Given this list of marker genes SLC8A1, SLC47A2, ARL2, RAB11FIP2, SLC38A2, RYR2, SLC22A4, ATP4A, SLC27A1, HMOX1, SLC25A4, TRPC7, NIPA1, SLC39A5, ANO4, GNG10, SLC41A2, ATP6V1A, SLC5A6, UBA52, CYBRD1, SLC24A1, ATP6V1E2, SLC17A7, SLC25A5, AQP10, AQP7, APOB, FTH1 (ferritin heavy chain 1), SLCO4C1, PSMA2, GNAS, DERL1, PSMD14, SLC40A1, SLC29A2 (NCBI Gene Id 3177), MCOLN2, ABCG8, PHB2, SLC26A6, SLC35D1, ABCD3, SLC26A11, CLCN6, ATP6V0A4, ABCC11, NGB, TRPA1, ATP2A2, LETM1, SLC3A1, ATP1A2, APOBR, UBB, ADRM1, PEX19, FXYD6, WNK2, SLC17A3, GLRX3, APOA2, VDAC2, EMB, GNB3, ATP8B1, SLC8A2, A2M, SLC22A6, DERL3, SLC5A11, CLCA1, BMP1, ABCB8, ATP6V1G2, EIF2S1, SLC15A4, SLC5A4, SLC30A10, ANO9, ESYT2 (extended synaptotagmin 2), SLC27A4, ATP4B, MIP, FXYD1 (NCBI Gene Id 5348), SLC8A3, SLC20A1, SLC25A6, PSMA7, PLEKHA8, SLC17A1, SLC31A1, SLC7A5, ANO3, SEL1L (SEL1L adaptor subunit of SYVN1 ubiquitin ligase), ATP6V1F, ATP9A, ADD3, SLC1A7, ERLEC1, AP2A2, SGK3, TPCN2, ABCB7, ATP6V1G3, ATP6V0D2, RNF185, MMGT1, SLC7A2 (solute carrier family 7 member 2), SPG7, GNG11, ABCC3, SLC26A9, APOC3, ADCY3, LIPA, SLC7A8 (NCBI Gene Id 23428), CIDEC, SAR1B, SLC26A3, ATP11B, ABCA5, SLC13A3, SLC43A2, SLC2A12, ATP11A, CES3, SLC43A1, MCOLN3, CAMK2G, SLC2A4, SLC35A3, NPC1, SLC28A1, GPIHBP1, ABCB6, ATP6V1D, SLC38A1, SLC12A3, SLC35B3, PSMD13, CUTC, SLC39A7, SLC2A1, SLC6A6, SLC38A4, RUNX1 (NCBI Gene Id 861), CLIC2, SLCO1C1, ATP2A1, BSG, ATP1B1, PSMC1, ANGPTL3, SLC2A6, SLC24A3, MBTPS2, PSMB7, TRPM4, HEPH, FTMT, RIPK1, IREB2, ASIC1, ABCG4, SLC45A3, STEAP4, ANO5, ATP1A3, SCARB1, EIF2S2, PSMC6, MYO5B, WNK4, SLC2A2 (NCBI Gene Id 6514), SLC7A3, ACO1, MAGT1, SLC39A6, FGF21, HBB, ANKH, CYGB, PRKAR2A, SLC44A4 (NCBI Gene Id 87892), SLC8B1, AVP, SLC25A11, SLC39A14, FURIN, PSMC2, PCSK6, PSMB2, CPTP, AKAP1, ATP2B1, SLC38A3, SLC6A15, ABCA10, SLC17A5, AP2A1, PSMA1, SOAT2, SLC38A5, DERL2, SLC9A6, SLCO2A1, SLC4A4, PSMB4, SRI, SLC30A5 (solute carrier family 30 member 5), SLC9A8, SLC1A5, SLC9B1, CLN3, CYB5R4, WNK1, PSMC3, NIPAL4, PSMB6, SLC25A22, NCEH1, SLC5A3, SLC22A3, CAMK2D (NCBI Gene Id 817), PSMA3, MIR32, SLC17A6, LMF2, APOC4, APOC2, ASIC5, APOA4, UBC, NR1H3, ABCA8, AP2S1, PRKACG, TF, SLCO2B1, ALAD, CYB5R2, TRPM3, AQP12A, GNG8, SLC16A7, TRDN, ATP8B4, TRPV3, RHAG, PARL, STOML3, SLC12A5, ADCY5, SLC1A1, BEST2, AQP5, SLC34A2, NPC2, ABCG2, ATP8A1, ATP2A3, TRPV2, RIPK3, SLC6A1, ABCC6, SLC16A8, GNB2, APOE, SLC9A9, GNG3, OS9, ATP6V1H, ATP9B (ATPase phospholipid transporting 9B (putative)), CSN1S1, TRPC4, ABCA6, UNC80, CLCA4, SLC24A5, SLC5A8, APOA1, SLC22A17, ATP2C2, SLC22A1, SLC67A1, GNG5, SLC4A1, PSMD11, SLC39A2, SLC4A2, SLC1A2, SLC25A29, ATP10A, CLCN3, AZGP1, CASQ2, FXYD2, LSR, TFRC, FXYD4, CUL1, SLC4A10, HDLBP, AHCYL2, SLC29A1, ATP6V0E1, RHBG, ADCY6, SCNN1G, SLC30A3, SLC7A10, MICU3, TTYH1, SLC2A10, DMTN, SLC7A7 (NCBI Gene Id 9056), RYR1, ATP6V1C1, ABCD1, TRPV6, SLC24A4, LRRC8B, SLC15A1 (NCBI Gene Id 6564), AQP6, FXYD3, CLCN5, SLC29A4, BEST4, SLCO1B1, SLC9A2 (solute carrier family 9 member A2), AQP11, ERLIN1, SEM1, ATP2B4, MB (myoglobin), ATP13A2, ATP6V0C, CAMK2A, CLTA, PCSK9, CREB3L3, LRRC8D, ADCY2, ATP1B2, ABCG1 (NCBI Gene Id 9619), PSMD3, SLC5A10 (solute carrier family 5 member 10), PEX3, MICU2, CLCA2, SLC5A5, SLC26A4, LIPG, PSMB5 (proteasome 20S subunit beta 5), TUSC3, CTNS, SLC10A6, PSMC5, ABCC5, MICU1, SLC34A3, TRPV1, ABCG5, GNB4, RPS27A, TRPM8, RAB11A, PSMD7, ATP6V1B2, VDAC3, NIPAL2, SLC2A14, SLC44A2, HFE, PSMD1, SLC7A1, TRPM5, ARL2BP, ANGPTL4, SLC22A11, FLVCR1, EIF2S3, ATP6V0D1, ATP10B, RAF1, SLC44A1, TRPM6 (transient receptor potential cation channel subfamily M member 6), SLC6A12, ABCA12, SCNN1D, LDLR, AQP8, ABCB10, FBXL5, CETP, VDAC1, TPCN1 (two pore segment channel 1), RYR3, SLC22A16, ANO7, TRPC4AP, LRRC8E, SLC22A5, NIPAL3, TRPV5, CSN3, TRPM7, HMOX2, SLC34A1, AFG3L2, SLC9A3, ABCF1, CA2, BSND, SLC9A7, PLTP, NEDD4L, SLC25A10, SKP1, SLC6A11 (solute carrier family 6 member 11), SLC5A2, PRKAR1A, SLC2A8, HBA1, ADCY1, ANO6, SLC2A7, SLC17A8, CLCNKA, SOAT1, SLCO3A1, NIPAL1, ATP2C1, SLC9C1, SLC30A8, SLC60A2, SLC22A7, CA1, ATP13A1, CLCN4, TCIRG1, ATP7A, PIP, ATP13A5, ABCA3, ANGPTL8, SLC9B2, ATP13A4, ARF1, SLC2A9, ATP6AP1, ABCB9, SLC30A1, GNGT2, PSMD12, SLC5A12, SLC2A3, PLN, SLC28A3, SCNN1B, LIPC, SLC13A2, ATP2B3, ADCY9, SLC16A1, SLC6A7, CYB5RL, SLC3A2, PCSK5, ATP1A4, SLC4A7, PSMA5, LDLRAP1, SLC39A4, SLC15A3 (NCBI Gene Id 51296), SLC25A26, SCNN1A, LMF1, TRPV4, LCN15, CALM1, SLC30A2, GNG7, SLC22A8, ADD2, NEDD8, PSMA4, ATP10D, SLC16A10, ASPH, SLC16A3, P4HB, PRKACA, MYLIP, SLC1A3, PSMC4, TRPC3, TFR2, AQP2, ATP6V0E2, SLC35B2, ABCA1, MCU, AVPR2, ABCB5, SLC9C2, ATP6V0B, CLTC, ADCY8, RSC1A1, SLC7A9 (solute carrier family 7 member 9), SLCO1B3, ERLIN2, SLC6A9, ASIC2, GLTP, SLC25A18, LRRC8C, SGK1, ABCD2, SLC26A2, PSMD2, SLC4A9, ABCC1, AQP1, PSMB3, APOD, CAND1, SLN, SLC36A1, PSMB1, SLC12A1, ANO1 (anoctamin 1), SLC4A3 (solute carrier family 4 member 3), SLC14A2, GNB1, SLC26A7, ANO10, SLC4A8, SLC6A3, SLC13A4, CYB5R1, SGK2, SLC26A1, ESYT3, ATP6V0A1, LCN9, SLC46A1 (NCBI Gene Id 113235), BEST3, ATP6V1E1, SLC12A2 (solute carrier family 12 member 2), SLC7A6, CA4, ABCC10, ATP8B2, SLC6A20, SLC6A5, SLC13A5, CAMK2B, SLC12A6, ABCA7, LCN2 (lipocalin 2), ABCC9, TTYH3, ANO2 (NCBI Gene Id 57201), STOM, ATP1B3, ATP6V1B1, SLC14A1 (NCBI Gene Id 6563), LCN1, SLC9A4, SLC20A2, PSMD8, ATP1A1, AQP3, SLC4A5, OSTM1, ABCB4, RNF5, GNG4, SLC2A11 (solute carrier family 2 member 11), ATP11C, LRRC8A, NALCN, AQP4, SLC36A4, ABCC4, CP, VLDLR, CUBN, ABCB1 (ATP binding cassette subfamily B member 1), GNG2 (G protein subunit gamma 2), STOML2, CLCNKB, YME1L1, WWP1, MRS2, MCUB, SLC39A3, CLCN7 (chloride voltage-gated channel 7), SLC35C1, CFTR, TTYH2, TRPC6, SLC35A1, TRPC5, GNG13, SLC27A6, APOA5, NR1H2, ESYT1, SLC1A4, SLC16A2 (solute carrier family 16 member 2), SLC5A7, ADCY7, SLC32A1, LCN12, MBTPS1, SMDT1, ASIC4, CASQ1, ATP6V0A2, PMPCA, FTL, MCOLN1, STEAP3, ABCC2, ABCA2, ATP8B3, SLC66A1, SLC1A6, FKBP1B, SLC36A2, SLC13A1, ASIC3, LPL, PRKAR2B, SLC22A2, SLC9A5, AMN, GNGT1, PMPCB, CLCN2, SLC2A13, GNG12, LCAT, AP2M1, ADD1, ZDHHC8, SLC24A2, SLC35A2, PSMD6 (NCBI Gene Id 9861), SLC6A19, ADCY4 (adenylate cyclase 4), TRPM2, PRKAR1B, SLC39A10, SLC35D2, SLC5A9, ATP2B2, SLC11A1, SLCO4A1, GNB5, RHCG, SLC6A13, SLC41A1, PHB1, FXYD7, MTTP, ATP12A, SLC50A1, VCP, APOC1, PRKACB, ABCA9 (ATP binding cassette subfamily A member 9), ATP7B, SLC22A15, SLC12A7, SLC39A1, PDZD11, SLC33A1, SLC28A2, SLC9A1, SLC44A3, ATP6V1G1, NIPA2, ALB, LPA, ATP6V1C2, TRPM1, APOF, SLC7A11, TRPC1, UNC79, MAIP1, ANO8, SLC22A12, SLC29A3, CLCN1, BEST1, AQP9, SLC11A2, MLKL, SLC47A1, KCNJ11, TSC22D3, SLC35B4, SLC6A4, SLC6A2, ATP8A2, WNK3, SLC5A1, AP2B1, SLC25A1, PSMA6, ABCA4, SLC12A4, SLC6A14, SLC39A8, SLC44A5, SLCO1A2, here is a description of the gene set: By definition cells have a critical separation between inner (cytoplasmic) and outer (extracellular) compartments. This separation provides for protection, gradient assembly, and environmental control but at the same time isolates the interior compartments of the cell from energy resources, oxygen, and raw materials. Cells have evolved a myriad of mechanisms to regulate, and enable transportation of small molecules ascross plasma membranes and between cellular organelle compartments within cells. Reactome Pathway: Transport of small molecules species: Homo sapiens